The following is a description of a gene set: Human Gene Set: GOBP_SURFACTANT_HOMEOSTASIS species: Homo sapiens Any process involved in the maintenance of a steady-state level of a surface-active agent that maintains the surface tension of a liquid., and this is the list of marker genes: RCN3, SFTPD, NAPSA, OAS1, NKIRAS1, CTSH, EPAS1, ITGB6, ABCA3 (ATP binding cassette subfamily A member 3), TGFB1, ADGRF5, NKIRAS2, LPCAT1, VEGFA, KDR, MBL2, TMEM63B, TMEM63A, ABCA12, BPIFA1